Given this list of marker genes PPL, LAMB1, SLC16A5, RARG, GTF2IRD1, CHST15, CDYL2, PSCA, SLC29A3, EFNB2, PTPN14, EPS8, ST8SIA4, YPEL3 (yippee like 3), EFNA1, MEF2D, FAXDC2, GPD2, SYTL2, LETMD1, IGSF3 (immunoglobulin superfamily member 3), AFAP1L2, BCL2L1, NPAS3, UBE2H, CDK6, KLF9, PLPP3, CDH3, DBP, YPEL2, CGN, PDK4, VPS9D1, BLNK, ATP1B1 (ATPase Na+/K+ transporting subunit beta 1), SASH1, INSIG2, ARID5B, TRIM52, ALAD, SLC22A23, CLDN9, ZDHHC7, SHROOM3, SPATA7, SEMA3E, LRATD2, PTPN21, MKX, IL1R1, NRP1 (NCBI Gene Id 8829), PLEKHF1, S1PR3, ZNF277 (zinc finger protein 277), TGFB2, TLE1, KIAA0513, EHF, ESR1, CREB3L2, ABCC5, TRIM45, GABBR2, EDN2, LMBRD1, DLL1, CFAP206, PSD3, ZKSCAN1, RBL2, SNTB2, GALNT10 (polypeptide N-acetylgalactosaminyltransferase 10), BCAR3, RAB18, GRHL1, ZMYND8, CPEB4, ATP8B2, HBP1, TNC, RNF144B, here is a description of the gene set: Human Gene Set: BHAT_ESR1_TARGETS_VIA_AKT1_DN studied in species Homo sapiens Estrogen regulates several biological processes through estrogen receptor alpha (ERalpha) and ERbeta. ERalpha-estrogen signaling is additionally controlled by extracellular signal activated kinases such as AKT. In this study, we analyzed the effect of AKT on genome-wide ERalpha binding in MCF-7 breast cancer cells. Parental and AKT-overexpressing cells displayed 4,349 and 4,359 ERalpha binding sites, respectively, with approximately 60% overlap. In both cell types, approximately 40% of estrogen-regulated genes associate with ERalpha binding sites; a similar percentage of estrogen-regulated genes are differentially expressed in two cell types. Based on pathway analysis, these differentially estrogen-regulated genes are linked to transforming growth factor beta (TGF-beta), NF-kappaB, and E2F pathways. Consistent with this, the two cell types responded differently to TGF-beta treatment: parental cells, but not AKT-overexpressing cells, required estrogen to overcome growth inhibition. Combining the ERalpha DNA-binding pattern with gene expression data from primary tumors revealed specific effects of AKT on ERalpha binding and estrogen-regulated expression of genes that define prognostic subgroups and tamoxifen sensitivity of ERalpha-positive breast cancer. These results suggest a unique role of AKT in modulating estrogen signaling in ERalpha-positive breast cancers and highlights how extracellular signal activated kinases can change the landscape of transcription factor binding to the genome. Genes bound by ESR1 and down-regulated by estradiol in MCF-7 cells (breast cancer) expressing constitutevly active form of AKT1. from publication Bhat-Nakshatri P, Wang G, Appaiah H, Luktuke N, Carroll JS, Geistlinger TR, Brown M, Badve S, Liu Y, Nakshatri H (PMID 18838536)